Given this list of marker genes COL4A3, NUP155, KCNK5, TBX19, NSD3, RADIL, MYBPC1, SEPHS2, LRRC57 (NCBI Gene Id 255252), EBF2, PPM1E, WHRN, DTNA, GEN1, NCKAP5 (NCBI Gene Id 401013), CASK, FEZF2, CHD6, OXNAD1, UPK2, ASCL3, POLD4, TACR1, SMPX, CCDC91, COL4A4, GSTA4, KRTCAP2, SLC44A1, SCNN1A, RBM11, NMUR2, MYH6, MFAP2, MGAT4C, RNF19B, BMP5, NEO1, PDE3B, SMAD1, WNT8B, FOXP2, TMEM59 (transmembrane protein 59), EIF4G1, PCDH8, JADE1, USP32, SOBP, EDNRA, DPH3, TAL1, SGMS2, MXD4, RCOR2, TRPM1, LRRN4CL, MYPN, CDK14, TGIF1, ETV1, PRDM2, TRIM54, TBC1D21, PCDHGB2, CXXC4, TSPAN16, ABHD1, ARID5A, SULF1, ZFPM2, SRSF6, NXF1, GAN, HOXB7, NRN1L, PTGFR, PATL1, ANXA6, AHR, TRIML1, RORA, TMEFF2, SEMA6A, ARHGAP17, NTRK2, ABCG5, MMAA, PRMT9, WT1-AS, PHOX2B, ESCO1, ATP6V1E2, TAF15, BCL2L2, JARID2, TESK2, ZNF322P1, ARHGAP21, ICAM5, SMOX, LHX6 (LIM homeobox 6), DMD, SAV1 (NCBI Gene Id 60485), GFI1, UNC5C, ABCG8, CACNG3, ERBB4, MASP1, TFIP11 (NCBI Gene Id 24144), ISCA2, ENPEP, PAPPA, DDX6, PPM1L, GAS2, RGS8, HMGN3, MAP4K4, GLRA2, HOXD10, WBP1, ACTN4, PLAG1, VNN2, NTRK3, PSMA1, SPARC, NMT2, JUND, ARHGAP12, SRSF1, RBM24, TTLL3, ELAVL2, OTX2, HNRNPA0, MAP3K20, CACNG2, ATP13A4, NREP, PRDM12, RPS6KB1, CNBD1, CD109, MYLK, IRX2, ADCY8, TNIP1, HIVEP1, RND1, ARHGAP11A, RALBP1, NCKIPSD, SERPINB12, SMC6, TRA2A, TAOK2, TMEM35A (transmembrane protein 35A), HAUS2, IRX4, ELOA2, RGS6, OTUD7B, MPV17, CYP2W1, MEIS2, CRK, NRP1, TTLL6, FLI1, SREK1, NRXN3 (neurexin 3), ACKR3, ADGRG4, WNT3, FSTL1, EVX1, PCDH9, ERN1, IL1RAPL1, MEOX2, FGF17, C18orf54, TBK1, MINDY1, PALS2, PHF3, CALD1, VIT, HDLBP, PID1, ABCA12, MSR1, NPC2, GNL3LP1, LHX5, SNX6, IGF2-AS, BMP10, LEMD1, TBL1XR1, TCEANC2, HOXC10, TMEM52B, PICALM, TMEM255A, UBE2V1, CTNND1, TRPS1, SP7, CGN, AAR2, FN1, PCDHA6, TRIM46, HAPLN1, NSD1, MBNL1, RAPGEF4 (Rap guanine nucleotide exchange factor 4), BAG3, ANKRD7, ADGRB3, POU3F4, DPF2, KCNJ13, CXCL14, GAD1, ALKBH6, LMO1, LRP1, ZBTB18, MYOCD, CHD2, LINC01565, SLC5A3, TENM1, MLLT10, SP6, JMJD1C, TRIM8, GSR, SPRY4, HOXB6, LRRN1, CPNE1, CD79B, FGF13, SEPTIN5 (NCBI Gene Id 5413), WWP2, LINC03122, here is a description of the gene set: Human Gene Set: AP3_Q6 species: Homo sapiens Genes having at least one occurrence of the motif TCYMMATT in the regions spanning 4 kb centered on their transcription starting sites. This matches the transcription factor binding site V$AP3_Q6 (v7.4 TRANSFAC).